Given this list of marker genes Il1b, Nfkb1, Ifng, Vdr (NCBI Gene Id 22337), Cyp27b1, Tnf, Gfi1, here is a description of the gene set: Any process that modulates the rate, frequency or extent of calcidiol 1-monooxygenase activity. Calcidiol 1-monooxygenase activity is catalysis of the reaction: calcidiol + NADPH + H+ + O2 = calcitriol + NADP+ + H2O. studied in species Mus musculus Mouse Gene Set: GOBP_REGULATION_OF_CALCIDIOL_1_MONOOXYGENASE_ACTIVITY